The following is a description of a gene set: species: Mus musculus from publication Chen Y, Wang X (PMID 31504780) Genes predicted to be targets of miRBase v22 microRNA mmu_miR_153_5p in miRDB v6.0 with MirTarget v4 prediction scores > 80 (high confidence targets). Mouse Gene Set: MIR_153_5P, and this is the list of marker genes: Skp2, Pcdh7, Frk, Ppat, Cyp2c55, Nova1, Rfx6 (regulatory factor X, 6), Brcc3, Lrrc4, Abce1, Cap2, Saxo2, Rbak, Aak1 (AP2 associated kinase 1), Fign, Apaf1, Fyb1, Bcl11a, Onecut3, Trpm3, B3gnt5, Yy1, Npas3 (NCBI Gene Id 71644), D430041D05Rik, Nsd3, Hsf5, Homer2, Spred1, Atp11c, Strbp, Fem1b, Runx1t1, A830018L16Rik, Tfap2d, Btg2, Etv1, Lamp2, Usp25, Dpyd, Aqp4, Zfp36l1, Tafa1, Tut7, Exo5, Ythdc2, Gphn, Cst7, Fbn2, Nktr, Zic3, Skil, Zfp11, Acer3, Zbed6, Arih1, Nmrk1, Glis3, Cxadr, Col11a1, Sfi1, Camk4, Cdh19, Inpp5f, Sqle, Itm2b, Stk3, Smim13, H2bc23, Rab8b, Dmxl2, Cep15, C2cd5, Serpina12, Smurf2, Pja2, Amd2, 1700018F24Rik, Spata31e5, Shroom2, Cdc14a, Cxxc4, Cnksr2, Rnf139, Rufy2, Qki, Slc38a2, Fas, Zbtb10, Tesmin, Deptor, Bnip2, Usf3, Arb2a, Btg4, Kremen1, Elapor2, Pogz, Nqo1, Dock2, Spata9, Aldoart1, Tsc22d2, Tead1, Trim68, Gpcpd1, Necab1, Rbm41, Aatf, Spata18, Spag9, Clec9a, Prl5a1, Olfm3, Lctl, Gpr180, Tmem17, 0610030E20Rik, Trhr, Fam199x, Lrrc14b, Cntln, Igip, Cacnb4, Phf11d, Spire1, Ttc14, Srpk2, Prkaa2, Srsf10, Serpinb13, Cebpg, Pkdcc, Gucy1a2, Ly86, Dmc1, Yme1l1, Tmem167, Eif4b, Arvcf, Tmem175 (NCBI Gene Id 72392), Dhx36, Lamc1, Tmem233, Trps1, Zbtb1, Atg14, Dzank1 (NCBI Gene Id 99097), Tnfsf11, Dnaja1, Arf4, Ankrd17, Znrf3, Idh1, Prl4a1, Nxph2, Nlgn1, Tmed5, Cibar1, Mfap3l, Mdga2, Olig3, Mccc2, Trpc5, Zfp157, Entpd1, Mycs, Tm7sf3, Mfap3, Mcur1, Dio2 (deiodinase, iodothyronine, type II), Rab27b, Jchain (NCBI Gene Id 68287), Smr2l, Stag1, Elavl4, Ttf1, Tmed2, Slc17a5, Ednrb, Tenm4, Tnfsf15, Rtn4, Slc49a4, Lamp5, Rps6ka6, Kcnip1, 4930523C07Rik, Myog, Rad54b, Fam210a, Agmo, Cblb, Cldn8, Tph2, Col19a1, Taok3, Cryba4, Cat, Clec4a2, Cnot4, Scel (sciellin), Slc25a46, Sap30bp, Hacl1, Pdzd8, Ntaq1, Atp2b3, Vmn1r58, Rsbn1, Epha7, Hs2st1, Zfp35, Ryk, Fut9, Slc26a10 (NCBI Gene Id 97639), Creb5, Mtdh, Ago1, Cdc73, Ssh2, Dbt, Hipk1 (homeodomain interacting protein kinase 1), Srsf1, Crmp1, Adamts20, Nppc, Gsx2, Prc1, Tafa2, Ric1, Hs6st2 (NCBI Gene Id 50786), Ophn1, Ptger3, Ano5, Frmd4b, Dhrs4 (dehydrogenase/reductase 4), Slc16a4, Ikzf5, Gpr34, Sp4, Chd9, Hrnr, Trib1, Pank3, Adamts6, Rab11fip2, Rora, Gm4871, Gpr22, Lrrtm3, Xpo7, Pard6g, Ccdc68, Osbpl3, Mgat4c, Cnih1 (NCBI Gene Id 218969), Ebf2, Sorbs1, Srebf1, Adhfe1, Arl4a, Slc39a14, Akap5, Tial1, Vegfc, Thada (thyroid adenoma associated), Aoah, Robo2 (roundabout guidance receptor 2), Pkp2, Rad51d, Prrg3, Fmn2 (NCBI Gene Id 98584), Crem, Themis, H2bc24, Dse, Wdr73, Pik3c2b, Crispld1, Fshb, Camta1, Anp32e, Sirt1, Lin28b, Lcp1, S1pr4, Tmem132b, Zswim6, Notch1 (notch 1), Lcn6, Lpl, Hsdl2, Phf20l1, Far1, 9330159F19Rik, Zfp384, Mxi1, Dcdc2a, Psmd5, Luc7l2, B3galt2, Sh3gl3, Pax9, Sorcs1, Chn1, Kcnma1, Smc6, Scn9a, Naa15, Ttll7, Rnf185, Slitrk6, Uba6, Invs, Ptchd4, Mbtps2, Mfsd8, D16Ertd472e, Cobl, Pde1a, Hormad1, Abca5, Hmgb3, Sptssb, Epha5, Ireb2 (iron responsive element binding protein 2), Myl12b, Gsk3b, Sephs1, Tapt1, Slc24a2, Tars2, Gpm6b, Mbnl3, Sema5a, Clcn3, Nrp1, Cntn4 (contactin 4), Pnisr, Tmem106b, Kcnn3, Snap25, Pou3f3, Ccnt2, Tulp4, Gpr141, Rnf44, Polr2m, Tfg, 4921517D22Rik, Tasor, Thrap3, Hdac9, Sgip1, Lix1, Gls, Pno1, Pde1c (NCBI Gene Id 18575), Mycbp2, Fchsd2, Stt3a, Sp1, Gask1b, Gnas, Ube2k, Spin4, Dab2, Ndufaf4, B230219D22Rik, Rhoq, Parp9, Ugdh, Tm9sf3, Mtf1, Creg2, Brinp2, Cracd, Mdm1, Pdcd6ip, Rab39b, Rbpj, Pabir2, Gatad1, P2ry12, Pappa, Tmem168, Negr1, Etnk1, Slc5a3, Gabra3, Mettl24, Qser1, Ugt2b35, Pln, Arfgef1, Map3k2, Lin7c, Mturn, Fxyd3, Habp4, Sp3, Map9, Ptbp2, Larp4 (NCBI Gene Id 52147), Rbbp8, Slc4a4, Apbb2 (NCBI Gene Id 69484), Trim33, Hycc2, Gusb, Herc3, Trim45, Arl5a, Prtg, Dennd4c, Abca1, Zfp512, Shroom3, Kctd8 (potassium channel tetramerisation domain containing 8), Pgrmc1, Lmo2, Tent5a, Lmln, Samd8, Greb1, Vgll3, Zbtb41, Usp38, Sim1, Acvr1c, Abi1, Abhd17b, Agps, Ncr1, Fbxo3, Ttc7b, Smarcc2, Caml, 1700066M21Rik, Nav1, Cul3, Frmd4a, Ankrd44, Itpr2, Nufip2, Nr1d2, Zdbf2, Nfat5, Myef2, Smim14, Cfi, Casp12, Creb1, Pramel47, Pan3, Nup37 (NCBI Gene Id 72714), Hhip, Aadacl2fm1, Krtap22-2, Phip (pleckstrin homology domain interacting protein), Arl5b, Hecw2, Sun3, Slc25a13, Fat3, Appl1, Scd2, Slc6a14, Nus1, Siglech, Atxn7, Pdzrn3, Acvr2a, Ccser2, Mmp27, Kifc3, Tfb1m, 1600012H06Rik, Erp44, Pum2, Prpsap2, Rwdd2b, Avl9, Tmf1, Thap1, Pfn2, Gabpa (NCBI Gene Id 14390), Xlr5a, Arl6, P4ha1, Nfib, Pgm2l1, Kctd1, Lratd2, Ccng1, Arhgap21, Hopx, Adamtsl1, Jade1, Bzw1, Tsfm, Rwdd2a, Ube3a, Scpep1, Rab3c, Prrx1, Zbtb44 (zinc finger and BTB domain containing 44), Scx, Trim2, Gpbp1, Tmem178b, Itga6, Nkain3, Pip4k2a, Snx25, Stxbp5, Otud6b, Mrpl50, Bmper, Hlf, Gpr155, Vps37a (vacuolar protein sorting 37A), Dynlt3, Sema4f, Rabgap1l, Ncoa5, Rabgef1, Tm4sf4 (NCBI Gene Id 229302), Gpat3, Seh1l, Gtdc1, Arid4b, Nap1l2, Rab33b, Ntrk2, Ddx21, Pou2f1, Eml4, 4930579G24Rik, Cyp2ab1, Pak3, Ankhd1, 1700017N19Rik, Kcne2, Rmnd5a, Zswim2, Cd84, Atrnl1, Acbd5, Cyp2j6, Oma1, Celf4, Vmn2r81, Vcan, Pate9, Igsf10, Mid2, Smim15, Macroh2a1, Fam120a, Klhl34, Scai, Nedd4l, Phactr2, Zfhx3, Grik2, Mocs2, Lrp6, Lpp, Tenm3 (teneurin transmembrane protein 3), Notch2, Bhlhe40, Necap1, Socs4, Ell2, Ambra1, Slc10a2, Fbxw7, Cnot2, Cd2ap, Mob1b, Dcun1d4, Tmem88, Xkr6, Marchf7, Ero1b, Nexmif, Snu13, Tfam, Ppp2r3a, Dmgdh, Nphp4, Dppa1, Ptprz1, Lmbrd1, Fut8, Khsrp, P2ry10b, Tmem229a, Adgrl4, Msl2, Zfp326, Amot, Tll1, Hook3, Arnt2, Csnk1g3 (casein kinase 1, gamma 3), Mal2 (NCBI Gene Id 223579), Atp2c1, Epha3, Lrrfip1, Itgad, BC051019, Epcip, Tet3, Csde1, 4933421I07Rik